Given this list of marker genes LGALS1, CLEC4D, SMIM14, TAF1D, RPL3, PSMB1, ANTXR2, RPL5, DHRS1, HEXA, TM2D2, TXNDC16, CTSH, JKAMP, FAM50A, ZDHHC14, TMED3 (transmembrane p24 trafficking protein 3), PLCB1, UTP3, KPNB1, GM2A, C1QC, CREG1, FOXO3, NICN1, CPSF7, UBAP1, RGS2 (NCBI Gene Id 5997), TRIAP1, LPIN1, CD28, CTDSP2, ATF3, MRPL45, TIMP3, TSPAN4, LAS1L (NCBI Gene Id 81887), HFE, TRAPPC3, PLIN2, ITGAX, FABP5, PPA1, CDK18, HACD3, RAB34, SPP1, NBR1, RTTN, CHCHD3, CD68, ALAS1, GBF1, CRTAP, ANXA1, ST6GALNAC4, GTF2B, CORO1B, PES1, LANCL1, PLBD1, PLTP, LGALS3, ADAM8, ACTG2, SPPL3, H1-2, GSTM5, EBP (NCBI Gene Id 139151), GJA1, BLNK, MMP12, TWSG1, PTGIS, PTGS1, PSMD6, THBD, COL4A1, GSN, CST3, CNN2, CYP1B1, LTA4H, ATG13, CSF1, CADM1, RPS6KA2, IL6ST, EVL, CDC16, DAGLB, CEBPZ, EIF3L, CD63, CSF2RB, CDKN1C, ACTG1, KDELR1, PARP2, PAGR1, GABARAPL1, ATP7A, PI4K2A, FTSJ3, NKAIN1, TUBB2A, GSTZ1, S100A1, PHLDB2, PITHD1, TMEM109 (NCBI Gene Id 79073), APOBEC1, CCR5, HGSNAT, CBX3, KPNA6, DNASE1L1, C1QA, SESN1, PER1, SRSF7, WBP1L, NES, RPL6, MFGE8, NDUFA3, RPL37A, DCN, APOE, ARID1A, MESD, IL7R, TCEAL9, CTSD, AKR1A1, CLTA, PITPNC1, ITGB5, MGST1, PTPRA, ADSS1 (NCBI Gene Id 122622), MORF4L2, LITAF, ATP5IF1, FOLR2, GLB1, HSD17B11, ANTKMT, LPL, B4GALT6, TEC (NCBI Gene Id 7006), TSC2, PDXK, CNIH1, ENTPD1, POR, TMEM106C, LSM4, PCCB, ANP32A, NDUFA5 (NCBI Gene Id 80046), PSAP, NT5DC3, SPSB1, MINDY1, UVRAG, FDPS, DCTN6, CNN3, LSS, CILP2, ABCB4, ARL8B, CD5L, DAP, C1QB, C3AR1, GNAS, ING4, KIAA0930, STX4, CTSB, GYG1, HBEGF, DAB2, KIAA0319L, PTK2B (protein tyrosine kinase 2 beta), POLR2A, CDT1, ANXA5, CCT3, MRPS12, SPSB2, MKNK2, ANGPTL2, OSBPL5, IGF1, LY86, PLPBP, HTRA1, here is a description of the gene set: The ability of dendritic cells (DCs) to activate immunity is linked to their maturation status. In prior studies we have shown that selective antibody-mediated blockade of inhibitory FcgRIIB receptor on human DCs in the presence of activating immunoglobulin (Ig) ligands leads to DC maturation and enhanced immunity to antibody-coated tumor cells. Here we show that Fcg receptor (FcgR) mediated activation of human monocytes and monocyte-derived DCs is associated with a distinct gene expression pattern, including several inflammation associated chemokines as well as type 1 interferon (IFN) response genes including the activation of signal transducer and activator of transcription 1 (STAT1). Genes up-regulated in dendritic cells versus monocytes. from publication Dhodapkar KM, Banerjee D, Connolly J, Kukreja A, Matayeva E, Veri MC, Ravetch JV, Steinman RM, Dhodapkar MV (PMID 17502666) Human Gene Set: GSE7509_DC_VS_MONOCYTE_UP studied in species Homo sapiens